The following is a description of a gene set: species: Mus musculus Mouse Gene Set: GOMF_PYRUVATE_DEHYDROGENASE_ACETYL_TRANSFERRING_KINASE_ACTIVITY Catalysis of the reaction: ATP + L-seryl- = ADP + H+ + O-phospho-L-seryl-., and this is the list of marker genes: Pdk2, Pdk1, Pdk4, Bckdk, Pdk3